The following is a description of a gene set: Human Gene Set: MCM5_TARGET_GENES species: Homo sapiens Genes containing one or more binding sites for (MCM5) in their promoter regions (TSS -1000,+100 bp) as identified by GTRD version 20.06 ChIP-seq harmonization. from publication Yevshin I, Sharipov R, Kolmykov S, Kondrakhin Y, Kolpakov F (PMID 30445619), and this is the list of marker genes: CTTNBP2, LINC01022, TMEM123, COL24A1, TBC1D3P6, VANGL1, HAPLN4, PAPLN